Given this list of marker genes Rhoa (NCBI Gene Id 51787), Ece1, Nos3, Edn2, Edn1, Edn3, here is a description of the gene set: species: Mus musculus The process in which endothelin modulates the force with which blood passes through the circulatory system. Endothelin is a hormone that is released by the endothelium, and it is a vasoconstrictor. Mouse Gene Set: GOBP_REGULATION_OF_SYSTEMIC_ARTERIAL_BLOOD_PRESSURE_BY_ENDOTHELIN